Given this list of marker genes TARBP1, TRMT44 (NCBI Gene Id 80015), ELP5, TSR3, DTWD1, CDKAL1, METTL6, URM1, QNG1, TRMT61A, TGS1, RAMACL, METTL4, APOBEC3C, SEPSECS, SNRPD3, APOBEC3B, NOP10, TYW3, NSUN5P1, BUD23, APOBEC3A, MRM1, YRDC, TRMT13, ELP6, WTAP, DPH3, TRMT1L, B3GNTL1, MTFMT, NHP2, TRMT6 (NCBI Gene Id 51605), ADAR, RPUSD4, TYW1, NSUN5P2, PUS7L, METTL14, OSGEP, MTO1, OSGEPL1, A1CF, TRMT9B, MRM3, AARS1, PUSL1, RPUSD1, RPUSD2, THADA, ADAT2, NSUN7, METTL16, DTWD2, PARN, BAG4, PUS10, TFB2M, TRMT10A, SNRPB, ADARB2, TRUB1, THUMPD1, TRMT61B, BCDIN3D, THUMPD2, THG1L, EMG1, MOCS3, METTL2A, RBM15, TRMT2B, TFB1M, RAMAC, TRMT1, TRUB2, DALRD3 (DALR anticodon binding domain containing 3), SARS1, ALKBH1, ADAD2 (adenosine deaminase domain containing 2), DUS1L, NSUN5, TRMT112, LCMT2, DUS2, CTU1, METTL25B, TRMT12, HENMT1, GAR1, TYW5, FDXACB1, THUMPD3, GTPBP3, SSB, NSUN4, RPUSD3, SNRPD2, FTSJ1, DNAJB11, AICDA, SNRPG (NCBI Gene Id 6637), LARP7, WDR4, APOBEC3H, AKT1, TRMT10B, TYW1B, NAF1, NSUN6, QTRT1, PUS7, METTL2B, RBM47, ALKBH8, TRMO, TRMT5, HSD17B10, ADAD1, FBL, KTI12, ELP3, TRIT1, TRMT10C, PUS3, MRM2, METTL15, ZCCHC4, APOBEC3F, SNRPD1, GTDC1, ANKRD16, NOP2, SNRPE, METTL5, SNRPF, SPOUT1, RNMT, QTRT2, APOBEC3G, ADARB1, ELP4, METTL8, ELP2, METTL3, METTL1, RBM15B (RNA binding motif protein 15B), TRDMT1, HNRNPAB, FTSJ3, SYNCRIP, DIMT1, DUS3L, APOBEC2, DKC1 (dyskerin pseudouridine synthase 1), JMJD6, GON7, NSUN2, NAT10, MEPCE, NSUN3, DUS4L, FBLL1, CTU2, PUS1, TRMU, APOBEC3D, METTL15P1, TPRKB, ELP1, APOBEC1, CDK5RAP1, WDR6, here is a description of the gene set: species: Homo sapiens The covalent alteration of one or more nucleotides within an RNA molecule to produce an RNA molecule with a sequence that differs from that coded genetically. Human Gene Set: GOBP_RNA_MODIFICATION